The following is a description of a gene set: The complex of RUNX2 and CBFB regulates transcription of genes involved in differentiation of osteoblasts.<br>RUNX2 stimulates transcription of the BGLAP gene, encoding osteocalcin. Binding of the RUNX2:CBFB complex to the BGLAP gene promoter is increased when RUNX2 is phosphorylated on serine residue S451. Osteocalcin, a bone-derived hormone, is one of the most abundant non-collagenous proteins of the bone extracellular matrix. Association of the activated androgen receptor (AR) with RUNX2 prevents binding of RUNX2 to the BGLAP promoter. When YAP1, tyrosine phosphorylated by SRC and/or YES1, binds to RUNX2 at the BGLAP gene promoter, transcription of the BGLAP gene is inhibited. Signaling by SRC is known to inhibit osteoblast differentiation.<br>Simultaneous binding of RUNX2 and SP7 (Osterix, also known as OSX) to adjacent RUNX2 and SP7 binding sites, respectively, in the UCMA promoter, synergistically activates UCMA transcription. UCMA stimulates osteoblast differentiation and formation of mineralized nodules.<br>The SCF(SKP2) E3 ubiquitin ligase complex inhibits differentiation of osteoblasts by polyubiquitinating RUNX2 and targeting it for proteasome-mediated degradation. This process is inhibited by glucose uptake in osteoblasts. Reactome Pathway: RUNX2 regulates osteoblast differentiation studied in species Homo sapiens part of: RUNX2 regulates bone development, and this is the list of marker genes: CBFB, HDAC3, WWTR1, SATB2, ZNF521, RB1, SP7, YAP1, HEY2, HDAC6, MAF, YES1, AR, MAPK1 (NCBI Gene Id 5594), ABL1, SRC, HES1, GLI3 (NCBI Gene Id 2737), RUNX2 (RUNX family transcription factor 2), UCMA, HEY1, COL1A1, BGLAP, MAPK3